Given this list of marker genes MTCH1, KCNB1, SCLT1, CNTNAP2, GLDN, MYOC, KCNIP2, PICK1, SPTBN4, NRCAM, CNTN2, AGRN, here is a description of the gene set: The process in which voltage-gated ion channels become localized to distinct subcellular domains in the neuron. Specific targeting, clustering, and maintenance of these channels in their respective domains are essential to achieve high conduction velocities of action potential propagation. studied in species Homo sapiens Human Gene Set: GOBP_NEURONAL_ION_CHANNEL_CLUSTERING